Given this list of marker genes Tnip2, Rora, Tnip3, Irgm1, Tnfaip3, Cactin, Tmc8, Rnf31, Cyld, Igtp, Nkiras2, Zc3h12a, Nfkbia, Ripk1, Esr1, Ppm1b, Trim59, Mapkbp1, Slc39a8, Ikbkg, Tnip1, Stat3, Nfkbid, Tgfbr3 (NCBI Gene Id 73753), Sirt1, Nr1h4, Sharpin, Irgm2, Sbno1, Nlrc3, Dab2ip (NCBI Gene Id 98996), Rhoh, Arrb2, Snip1, Nlrp6, Nlrx1, Rhoa, Sirpa, Uaca, Hdac1, Usp10, Nkiras1, Trim39 (NCBI Gene Id 79263), Lilrb4b, Otud7b (OTU domain containing 7B), Tank, Chuk, Lilrb4a, Nlrp12, Map2k5, Gstp1 (glutathione S-transferase, pi 1), Tradd, Trem2, Nfkbil1, Nr1d1, Olfm4, Usp20, Chrna7, Tmsb4x, Tnf, Dnaja3, Tnfrsf1a, Traf2, Optn, Casp8, Stat1, Azi2, Pycard, Adipoq, Per1, Ppm1a, Klf4, Birc2, Rbck1, Tle1, Irak2, Irak3, Ccdc22, Ikbkb, Tspan6, Riok3, Zmynd11, here is a description of the gene set: Any process that stops, prevents, or reduces the frequency, rate or extent of a canonical NF-kappaB signaling cascade. studied in species Mus musculus Mouse Gene Set: GOBP_NEGATIVE_REGULATION_OF_CANONICAL_NF_KAPPAB_SIGNAL_TRANSDUCTION